Given this list of marker genes KHDRBS2, BLNK, NLK, SH2B2, KHDRBS1, RACK1, SYK, SLAMF1, SQSTM1, AFAP1L2, LAT2, CTR9, JAK2, KIT, FGFR1, LCK, SH3PXD2B, RUFY1, DAG1, LILRB1, PTK2, SRC, CRK, TRPV4, GHR (growth hormone receptor), ABL1, SKAP1 (NCBI Gene Id 8631), SYNGR3, SHCBP1, LAX1 (NCBI Gene Id 54900), DLC1, SYP, NUP62, SIGLEC10, PTPN6, SIT1, PAG1, INPPL1, IRS1, ARHGAP5, CCDC88A, here is a description of the gene set: Human Gene Set: GOMF_SH2_DOMAIN_BINDING species: Homo sapiens Binding to a SH2 domain (Src homology 2) of a protein, a protein domain of about 100 amino-acid residues and belonging to the alpha + beta domain class.